Given this list of marker genes DHX40, SKIC2, DHX9, DHX38, AQR, YTHDC2, SUPV3L1, here is a description of the gene set: Unwinding of an RNA helix in the 3' to 5' direction, driven by ATP hydrolysis. species: Homo sapiens Human Gene Set: GOMF_3_5_RNA_HELICASE_ACTIVITY